Given this list of marker genes ARFGEF1, TECTA, LIN54, RBM39, FERD3L, TSPAN13, PAQR7 (NCBI Gene Id 255358), MAML3, VAX1, SFN, MIR9-1HG, SNX6, RIT2, PLAGL2, MGLL, TOR1AIP2, BCL2, MTF1, FOXP1, TRA2A, GPS2, B3GNT6, PDGFRA, CACNA2D3, ETV1, JPH1, MYRF, SARNP, PRKAG1, SYTL2, DSG1, GNAO1, TMEM175, DLGAP4, FSBP, SLC6A14, TSHZ2, ITPKB, PRMT6, CLCN6, KCNQ5, HOXA9, OTX1, ZBTB37, ORMDL2, DLK2, DLK1, MLLT10, RAB1A (NCBI Gene Id 5861), ADIPOQ, TWIST1, LMOD3, SRPK2, H4C3, CDCA7L, TCF4 (NCBI Gene Id 6925), MGAT4C, CDH6, LRRFIP2, TLE3, PAX8, UBE2H, JADE2, HOMER1, BRMS1, PLS1, MARK3, CEP120, BMP1, ASIC1 (NCBI Gene Id 41), PAX6, NLGN2, EGFR, CLDN1, KCND1, ITPR1, LINGO2, DYRK3, PURA, EYA1, ILF3, ZDHHC14, UBXN10, GPBAR1, CMTM4, CRY1, S100A16, OTP (orthopedia homeobox), RPE65, OTX2, ANGPT1, LRMDA, LUC7L3, KCNJ3, NEUROG1, PTPRO, NKX2-2, GCAT, ZNF410, CPEB4 (NCBI Gene Id 80315), AGO1, DSC3 (desmocollin 3), ODC1, FAM117A, MYL1, KLHL11, CAPSL, NEO1, ENSG00000228919, PPARGC1A, MSTN, HAUS3, KATNB1, DMD, PTBP2, MID1, AMTN, ARX, GSK3B, FIP1L1, ZIC4, RBM3, CFL2, CNTN1, KANSL3, IL21, SLC25A37, PAQR9, MTHFR, CNOT2, ADAMTS5, ZEB2, SLC6A11, EMCN, CDK2AP1, MGAT4B, PTCHD1, PYM1 (NCBI Gene Id 84305), SATB1, RFX3, PCIF1, PSMD11, RAB18, LINC00670, SARM1, JARID2, PPP2R2B, POU2F1, TFDP2, MXI1 (NCBI Gene Id 4601), ZNF532 (NCBI Gene Id 55205, zinc finger protein 532), LRRTM1, TOMM40L, AFAP1, NCAM2, HOXD13, SHANK1, IL1RAPL1, WNT16, SOX5, MAZ, ARHGEF11, POLA1, IMPDH2, BNC2, OSR1, PBX3, NSD1, CNNM2, WNT8B, FSTL1, PXN, SSBP3, BMI1, KCTD15, POGZ, HHEX, VPS16, GPBP1L1, UBE2D3, GPRIN3, TSGA10, HERC1, CNOT7, WASF2, GMPPB, MEF2C, NR0B2, TRPM3, ARL4C, SP1, CSMD3, NSRP1, CHRDL1, MAGI3, HOXC4, PIP4K2C, GOLM2, ADD3, POFUT1, KLF8, EGF, PRPF38B, LINC00649, VPS37A, LIX1L, OGN, EMSY, DACH2, GRM7, HIGD1B, UCK2, CCDC136, NUAK1, CLC, PTK7, SND1-IT1, TNRC6A, PPP2R5E, BMP10, CCDC24, ORAI3, SMARCA2, MLEC, TIAL1, GDF3, LHX6, ASIC2, GPM6A, MEOX2, TGIF1, ONECUT2, ASIC4, RRN3P1, SEPTIN9, AEBP2, FGF20, GUCY2F, FOXD3, PRCC, GPR119, PKP3, HOXB3, TGFB3, here is a description of the gene set: studied in species Homo sapiens Genes having at least one occurrence of the motif WCTCAAGTGT in the regions spanning 4 kb centered on their transcription starting sites. This matches the TITF1 transcription factor binding site V$TITF1_Q3 (v7.4 TRANSFAC). Human Gene Set: TITF1_Q3